Given this list of marker genes RASSF2, NRG1, CHP1, MOB1B, EPHA7, TOM1L1, NEK10, PDGFA, RAP2A, VEGFA, MVP, PDGFB, ERRFI1, ADIPOQ, here is a description of the gene set: studied in species Homo sapiens Human Gene Set: GOBP_REGULATION_OF_PROTEIN_AUTOPHOSPHORYLATION Any process that modulates the frequency, rate or extent of addition of the phosphorylation by a protein of one or more of its own residues.